Given this list of marker genes Ddx6, Tle3, Iqcd (IQ motif containing D), Mmp3, Cpt1b, Xcr1, Dnm1, Rcc2, 1700006J14Rik, Dync2i2, Arid5b, Nceh1, Mdn1, Nfam1, Ctrb1, Gsta4, Cdc37, Tomm20, Jun, Rragd, Mtdh, Tlx2, Cyp17a1, Aqp1, Eif3k, Tmem9, Cs, P2rx2 (NCBI Gene Id 231602), Crlf1, Naa10, H19, Lbr, Il3ra, Fthl17e, Myl3, Lalba, Rpl10a, Acbd6, Gabbr1, Syt10, Tubb2a, Eif3e, Sidt2, Nsa2, Lars2, Gbp5, 1110006O24Rik, Rpl31, Pcp2, 1700029F12Rik, Ahcy, Tapbpl, Mesp2, Lpar6, Rph3al, Blvrb, Terf1, Spen, Asl, Penk, Ola1, Mrps5, Tcp1-ps1, Zfp423, Ngef, Kif21b, Hipk2, Hs6st3, Bgn, Plod1, Tubb5, Raver2, Psd, Pou4f1, Utf1, Plpp3, Igbp1, Supt16, Khsrp, Rps18, Nap1l1, Cryz, Akap12, Cdkn1c, Zfyve27, Tcf7l2, here is a description of the gene set: species: Mus musculus Mouse Gene Set: BILANGES_SERUM_SENSITIVE_GENES from publication Bilanges B, Argonza-Barrett R, Kolesnichenko M, Skinner C, Nair M, Chen M, Stokoe D (PMID 17562867) The tuberous sclerosis complex (TSC) proteins TSC1 and TSC2 regulate protein translation by inhibiting the serine/threonine kinase mTORC1 (for mammalian target of rapamycin complex 1). However, how TSC1 and TSC2 control overall protein synthesis and the translation of specific mRNAs in response to different mitogenic and nutritional stimuli is largely unknown. We show here that serum withdrawal inhibits mTORC1 signaling, causes disassembly of translation initiation complexes, and causes mRNA redistribution from polysomes to subpolysomes in wild-type mouse embryo fibroblasts (MEFs). In contrast, these responses are defective in Tsc1(-/-) or Tsc2(-/-) MEFs. Microarray analysis of polysome- and subpolysome-associated mRNAs uncovered specific mRNAs that are translationally regulated by serum, 90% of which are TSC1 and TSC2 dependent. Surprisingly, the mTORC1 inhibitor, rapamycin, abolished mTORC1 activity but only affected approximately 40% of the serum-regulated mRNAs. Serum-dependent signaling through mTORC1 and polysome redistribution of global and individual mRNAs were restored upon re-expression of TSC1 and TSC2. Serum-responsive mRNAs that are sensitive to inhibition by rapamycin are highly enriched for terminal oligopyrimidine and for very short 5' and 3' untranslated regions. These data demonstrate that the TSC1/TSC2 complex regulates protein translation through mainly mTORC1-dependent mechanisms and implicates a discrete profile of deregulated mRNA translation in tuberous sclerosis pathology. Genes translationally regulated in MEF cells (embryonic fibroblasts) in response to serum starvation but not by rapamycin (sirolimus).